The following is a description of a gene set: Human Gene Set: GTCAACC_MIR3805P studied in species Homo sapiens Genes having at least one occurence of the motif GTCAACC in their 3' untranslated region. The motif represents putative target (that is, seed match) of human mature miRNA hsa-miR-380-5p (v7.1 miRBase)., and this is the list of marker genes: CREG2, ANKRD49, ITGA9, AKAP1, COLQ, HOXA1, COL1A2, PLAG1, HMGN2P46, FRMD4A, AEBP2, MDGA2, HMGN2, KMT2A, RNF111, FRAS1, MICAL2, KLHL13, VWC2, CD83, CLUH, TRIM2